The following is a description of a gene set: part of: G0 and Early G1 DREAM complex is evolutionarily conserved and is responsible for transcriptional repression of cell cycle-regulated genes in G0 and early G1. species: Homo sapiens Reactome Pathway: Transcription of E2F targets under negative control by DREAM complex, and this is the list of marker genes: RBL2, LIN54, E2F1, CDC25A, HDAC1, RBL1, MYC, RBBP4, TFDP2, LIN9, MAX, PCNA, TFDP1, CDC6, LIN37, LIN52, TOP2A, E2F5, E2F4 (NCBI Gene Id 1874)